Given this list of marker genes SIX1, EYA1, KCNJ10, HRAS (HRas proto-oncogene, GTPase), SIX5, PI4KB, FOXI1, SLC26A4, MAP3K7, here is a description of the gene set: Increased size of the vestibular aqueduct. species: Homo sapiens Human Gene Set: HP_ENLARGED_VESTIBULAR_AQUEDUCT Enlarged vestibular aqueduct